The following is a description of a gene set: Any process that activates or increases the frequency, rate or extent of tight junction assembly. species: Mus musculus Mouse Gene Set: GOBP_POSITIVE_REGULATION_OF_BICELLULAR_TIGHT_JUNCTION_ASSEMBLY, and this is the list of marker genes: Nphp1, Il17a, Cldn5, Nphp4, Cldn3, Epha2, Rac1, Acvrl1, Cldn1, Gdf2, Dsg3